Given this list of marker genes TPP1, CSF1R, CD38, NF1, ACP5, IAPP, GPR55, PTK2B, ADRB2, NCDN, CARTPT, TCIRG1, ITGB3, CLDN18 (claudin 18), PRKCA, SNX10, P2RX7, IL6, INPP5D, TNFAIP3, SLC4A2, SIGLEC15, RAC2, TRAF6, DEF8, ARAP1, RAB3D, SRC, FSHR, NOX4, CTNNB1, IL20RA, LRRK1, DCSTAMP, ADAM8, RAB7A, BBLN, UBASH3B, PLEKHM1, IHH, RUFY4, BGLAP, ZNF675, FSHB, PTH1R, CALCA, MC4R, CTSK, TNFRSF11A, TNFSF11, SPP1, S1PR1, LTBP3, TMEM64, GPR137B, TMEM119, SYK, PTH, GPR137, PDK4, IL7, EXT1, CSK, here is a description of the gene set: The process in which specialized cells known as osteoclasts degrade the organic and inorganic portions of bone, and endocytose and transport the degradation products. species: Homo sapiens Human Gene Set: GOBP_BONE_RESORPTION